The following is a description of a gene set: Human Gene Set: GOCC_EXTERNAL_ENCAPSULATING_STRUCTURE studied in species Homo sapiens A structure that lies outside the plasma membrane and surrounds the entire cell or cells. This does not include the periplasmic space., and this is the list of marker genes: SERPINB9, PRTN3, COL12A1, OMD, LRRTM3, USH2A, CRISP3, VTN, AMELY, DST (dystonin), MMP9 (matrix metallopeptidase 9), HPSE, CCN2, ORM1, MMP28, KRT1, ITIH5, ANGPTL5 (NCBI Gene Id 268275), APOA4, ANGPTL2, VEGFA, ZP3, MFAP5, CDH2, ACHE, MXRA5, EFEMP1, ADAMTS2, MMP23B, DAG1, S100A6, ELANE, COL10A1, HRNR, FLRT1, TINAGL1, FIBCD1, COL16A1, PLSCR1, APOE, CDON, COL9A3, FLRT3, ANXA2P2, MMP7, MARCO, COL24A1 (NCBI Gene Id 255631), HPX, SSC5D, DLG1, HMCN2, FBN3, S100A10, PCSK6, HSP90B1, CLC, ANXA7, PKHD1L1, P3H1, ITIH4 (NCBI Gene Id 3701), COL5A2, F9, SDC2, HDGF, HSPG2, LEFTY2, ZAN, CTSS, COL8A1, FBLN7, ADAMTS19, FBLN5, PCOLCE, ADAMTSL3, MGP, OLFML2B, HAPLN2, ANGPTL6, GFOD2, MMP3, C17orf58, COL4A6, AEBP1, S100A8, ADAMTS16, ZP2, LGALS3BP (galectin 3 binding protein), MFGE8, LAMB2, FN1, IL7, SERPINB6, CTSC, FMOD, LOX, GLG1, COL1A1 (collagen type I alpha 1 chain), AZGP1, DEFA1, LTBP1, MMP24, PHOSPHO1, CRELD1, MEGF9, TPSAB1, COL4A5, ENTPD2, HAPLN1, CRISPLD2, LRIG3, LOXL1, ADAMTS7, SPON1, EGFL7, BCAN, CD151 (NCBI Gene Id 977), THBS1 (thrombospondin 1), MMP27, LRRC15, CCN5, TNR, COL6A2, MMP25 (NCBI Gene Id 82110), CTSB, SERPINB12, VWA1 (NCBI Gene Id 64856), MMP14, COL7A1, MMP21, FGF10, OTOL1, EGFLAM, LAMC2, MFAP1, PLOD1, A1BG, CXCL12, PRG3, SMOC2, CFP, WNT5A, SRGN, LAMC1, OVGP1, AMELX, MUC17, PRG2, CASK, TPSB2, SDC3, SMOC1, TIMP1, CPA3, HAPLN4, UCMA, IFNA2, APOH, ELFN1, ANGPT2, ADAMTS5, SERAC1, BCAM, TINAG, TIMP3, PTX3, SERPINF1 (NCBI Gene Id 5176), LRRC32, COCH, ANXA1, ENAM, HSD17B12, LAMA5, PODNL1, ADAMTS9, COL5A3 (NCBI Gene Id 50509), FGF1, LAMA2, COL15A1, COL19A1, LMAN1, NID2, OGN, ALPL, MMP15, LOXL2 (lysyl oxidase like 2), EMILIN1, COL20A1, PF4, NAV2, HNRNPM, LRIG2, L1CAM, NID1, SOST, COLQ, EYS, MST1, SRPX2, ADAMDEC1, APOC3, FCN3, LINGO2, EPYC, LINGO1, LRIG1, CCN3, TNC, CBLN4, DCN, NDP, APCS, SPN, CCN4, NTN4, LRRTM4, MMP20, COL11A2, ECM2, MXRA7, CCN6, ANXA5, IGFBP7, ANOS1, ORM2, DMBT1, CCDC80, LGALS3, LRRC24, SRPX, SBSPON, ADAM11, PRSS2, FGL1, SERPING1, LRRN3, VIT, HTRA1, LAMB1, MATN1, INHBE, CLEC3B, HRG, COL27A1, FRAS1, MEPE (NCBI Gene Id 56955), GREM1, MMP17, CLU, PRG4, COLEC12, LTBP2 (latent transforming growth factor beta binding protein 2), ADAMTS20, MUC4, COL22A1, ANXA2, ZP1, FGL2, CHADL, THBS3, SULF1, GP1BA, EMID1, COL11A1, AGT, FCN1, CTSF, COL13A1, LAMA1, CMA1, APOA1, SPARC, MMP8, FGFR2, SNED1, CDH13, FLRT2, LGALS4, ADAMTSL5, SERPINC1, COL1A2, MATN3, ANXA11, CTSH, LAMC3, ANXA4, ADAMTS10, WNT2B, TGM4, ESM1, TNN, AHSG, COL26A1, S100A7, TNFRSF11B, OC90, SERPINE2, SERPINA3, TGFB3, ACTA2, CLIC3, COL25A1, SPP2, F12, COL3A1, ITGB4 (integrin subunit beta 4), S100A9, IGFALS, NCAN (neurocan), LRRC3C, LRRN1, SPOCK2, NYX, ELN, LINGO4, SERPINE1, COL9A2, TFPI2, KERA, GPLD1, LAMA3, CCN1, COMP, ELFN2, PLG, TGFB2, PODN, RTBDN, BGN, THBS4, COL18A1, FGB, LUM, TIMP2, ITIH2, COL6A5, DPT, DEFA1B, FGG, RELN, SPOCK1, FBN1, ADIPOQ, SPON2, VWF, LTBP3 (latent transforming growth factor beta binding protein 3), MMRN2, THBS2, MMP12, SERPINA5, WNT7A, GH1, FGA, ABI3BP, MATN4, LAMA4, DGCR6, MDK, MMP19, RTN4RL1, ADAMTSL2, VWC2, TGFB1I1, WNT8A, PZP, LGALS9, COL14A1, ANG, F3, FREM1, FCGBP, DSPP, ADAMTS18, ITIH1, VWA2, WNT3 (Wnt family member 3), TGFBI, EMILIN2, PI3, CTHRC1, ADAMTSL4, SPOCK3, RBP3, HAPLN3, TGFB1, GPC1, PKM, NTN1, OTOGL, ADAMTS13, ADAMTS4, COL6A1, ANGPTL7, MUC2, COL2A1, ADAMTS17, LOXL3, F7 (NCBI Gene Id 14068), TLR3, CTSL, TIMP4, CD248, ANXA6 (annexin A6), ZG16 (zymogen granule protein 16), LRRN2, CHAD, BMPER, FCN2 (NCBI Gene Id 2220), RELL2, ANGPT4, OTOG, ADAMTS1, CHI3L1, RTN4RL2, PDGFB, PRELP, SERPINH1, SEMA3B, C6orf15, ADAMTS12, EFNA5, FLG, CCBE1, POSTN, FREM2, ECM1, OLFML2A, ICAM1, MATN2, EFEMP2, MMP13, APLP1, ANXA8, COL6A3, NPNT, ANGPTL4, LRRTM1, ENTPD1, COL23A1, CILP, THSD4, GDF15, EMILIN3, FBLN1, KAZALD1, SERPINB8, ANGPTL3, LAD1, AGRN, WNT2, COL28A1, SLPI, MMRN1, WNT11, NDNF, MYOC, IGFBPL1, GDF10, LRRC17, F2, PLOD2, FBN2, ADAM19, IHH, LAMB4, WNT5B (NCBI Gene Id 84728), COL5A1, SEMA7A, C1QB, SOD3, SFRP2, LRRC3B, CPN2, HPSE2, EGFL6, MUC5B, AMBP, LINGO3 (leucine rich repeat and Ig domain containing 3), CD180, TECTB, WNT6, COL6A6, C1QC, MMP2, C1QA, NCAM1, CSPG4, CLEC14A, FREM3, TRIL, ADAMTS3, SHH, SERPINA1, PRSS1, MFAP2, PLOD3, MMP10, PLAT, MMP11, HMCN1, LMAN1L, CTSG, COL4A4, MFAP4, SFRP1, CSTB, TECTA, EDIL3, CTSD, MUC5AC, LGALS1, PSAP, KNG1, TFIP11, LTBP4, COL4A2, MUC6, IMPG2, COL9A1, ADAMTS15, MMP16, IMPG1, WNT4, RARRES2, ADAMTS14, ERBIN, LAMB3, TNXB, MMP26, A2M, COL4A1, SSPOP, P3H2 (prolyl 3-hydroxylase 2), PXDN, ADAMTS6, COL17A1, TGM2, SERPINF2, NPPA, S100A4, COL4A3, FGFBP3, FBLN2, VCAN, COL8A2, ANGPTL1, ADAMTS8, OPTC (opticin), COL21A1, F13A1, ZP4, VASN, MMP1, AMTN, DMP1 (dentin matrix acidic phosphoprotein 1), ASPN, LOXL4, ACAN, SERPINB1, ANGPT1, PTPRZ1, CTSZ, CBLN1